The following is a description of a gene set: Human Gene Set: GSE41176_UNSTIM_VS_ANTI_IGM_STIM_BCELL_3H_UP The activation signaling of transcription factor nuclear factor-kB (NF-kB) plays central role for immune system. One of key kinase mediating this pathway is TAK1 in adaptive and innate immunity. However, role of TAK1 in B cell receptor signaling is still unclear. To know effects of TAK1-deletion on the gene expression induced by anti-IgM, we performed the time course analysis in comparison of wild type with TAK1-deleted splenic B cells. from publication Shinohara H, Behar M, Inoue K, Hiroshima M, Yasuda T, Nagashima T, Kimura S, Sanjo H, Maeda S, Yumoto N, Ki S, Akira S, Sako Y, Hoffmann A, Kurosaki T, Okada-Hatakeyama M (PMID 24833394) species: Homo sapiens Genes up-regulated in B lymphocytes: untreated versus anti-IgM for 3h., and this is the list of marker genes: RAP2C, SRPRA, RGS16, ABCF1, F3, EHD1, IL2RA, DNAJB9, EREG, ARFGAP3, HAS1, TNFRSF1B, MT2A (metallothionein 2A), SLC15A3, UPB1, MARCKS (myristoylated alanine rich protein kinase C substrate), RHCE, TP53BP1 (tumor protein p53 binding protein 1), MT1H, NAMPT, CADM3-AS1, MEG3, PMEL, LRIG1, SLAMF7, CXCL5, ETV3, AK4, IER3, TNFAIP6, AMIGO2, FICD, YRDC, HYOU1, BAHD1, CUL4A, PCID2 (PCI domain containing 2), IL15RA, PLAUR, GLRB, CST2, EZH2, GPR137B, ACSL5, PPP3CC, IRAK3, RAB21, PGM3, CFLAR, MYO1B, MAFF, GPRC5C, PLA1A, TMEM185B, IL24, GRAMD2B, CEP135, GRM5, INSM1, TRIP10, PTX3, EHF, XBP1 (X-box binding protein 1), PDE8A, PFKFB3, SOD2, TUBAL3, SLC11A2, ANK3, HDAC9, WTAP, TBC1D30, AGK, MT1G, CDH13, BCL2A1, GSDME, IGSF3, DUSP2, IL12B, EGFL6, PLAC8, S100A7, MTF1, TNF, IL6, PMAIP1, VNN1, AGPAT4, SLC7A7, MMP7, NINJ1, ATP13A3, NDEL1, ALB, ST3GAL1, MAP3K4, MAP2K1, POLR3D, UBB, UXS1, IL19, ZC3H12A, TFRC, LYRM1, SLC2A6, PLGRKT, LAMP3, NFKBIB, WNT5B, CCL4, TXN, PTGS2, CRIM1, SEC61A1, CXCL3, ENTPD7, CYP3A5, RIN2, AQP9, MYH10, SLC43A3, PIGV, SUSD6, NPR3, TRAF1, COPG1, CXCL1, HHIPL2, FLT4, MAMLD1, CYB5R2, HRH1, PDIA5, IL36G, PLK3, MT1E, TMEM39A, ETS2, IL1A, IL1B, TNFAIP3, CCL20, CKB, ATP6V1H, PAGE1, MAP3K5, CXCL8, ITGB8, FPR2, GMPPB, MT1HL1, SNN, ABTB2, SINHCAF, IL23A, TECPR2, SMPDL3A, G0S2, TLCD3A, STK26, TNIP3, PDSS1, RBPMS, INAVA, SOCS3, SERPINB1, GK3, MRPL52, CHRND, IL7, HOXC11, BATF, DNAJA4, GRIP1, HEY1, PLAT, SLCO4A1, IL10, INHBA, STAT4, CXCL2, EBI3, TFPI2, INA, DNAAF1, ROBO1, FLT1, TNIP1, BTG3, MT1F, VNN3P, REXO5, MT1X, ZNF550, MMP14, AMPD3, RHOF, ACSL1